The following is a description of a gene set: Folds of membranous tissue (peritoneum, mesothelium) attached to the wall of the abdomen and enclosing viscera. Examples include the mesentery for the small intestine; the transverse mesocolon, which attaches the transverse portion of the colon to the back wall of the abdomen; and the mesosigmoid, which enfolds the sigmoid portion of the colon. Cells of the same embryologic origin also surround the other organs of the body such as the lungs (pleura) or the heart (pericardium). Human Gene Set: HP_ABNORMAL_MESENTERY_MORPHOLOGY studied in species Homo sapiens Abnormal mesentery morphology, and this is the list of marker genes: WFS1, DSE, MNX1, CISD2, CHST14, TMEM94